The following is a description of a gene set: studied in species Homo sapiens Diffusely large eye (with megalocornea) associated with glaucoma. Buphthalmos Human Gene Set: HP_BUPHTHALMOS, and this is the list of marker genes: SIX6 (NCBI Gene Id 4990), AKT1, DAG1, POMT2 (NCBI Gene Id 29954), SBF2, NDP, POMGNT1 (protein O-linked mannose N-acetylglucosaminyltransferase 1 (beta 1,2-)), TWIST1 (twist family bHLH transcription factor 1), MAB21L1, ATOH7 (NCBI Gene Id 54719), OCRL, LARGE1, FZD4 (NCBI Gene Id 8322), FUT8, LTBP2, MYOC, GNAQ, FGFR2, PXDN, TEK, GLIS3, SH3PXD2B, CYP1B1, ADAMTSL1, POMT1, FKTN, FKRP, NCAPG2